The following is a description of a gene set: mouse primary BMDCs were stimulated with tlr ligands and gene expression changes were profiled on Affymetrix arrays from publication Amit I, Garber M, Chevrier N, Leite AP, Donner Y, Eisenhaure T, Guttman M, Grenier JK, Li W, Zuk O, Schubert LA, Birditt B, Shay T, Goren A, Zhang X, Smith Z, Deering R, McDonald RC, Cabili M, Bernstein BE, Rinn JL, Meissner A, Root DE, Hacohen N, Regev A (PMID 19729616) studied in species Homo sapiens Genes up-regulated in comparison of dendritic cells (DC) stimulated with Pam3Csk4 (TLR1/2 agonist) at 0.5 h versus those stimulated at 4 h. Human Gene Set: GSE17721_0.5H_VS_4H_PAM3CSK4_BMDC_UP, and this is the list of marker genes: PELO, PRR15, ASB4, CNR2, HMGB2, TEX2, HCFC1R1, C1D, EXT1, COMT, LAMTOR1, CASQ1, RPF2, GALK2, CBX6, RNF34, DUS1L, ARHGAP23, GALM, EID1, HSPH1, CRAT, NIPSNAP1, POLR2E, TRIM7, FTSJ1, TXNDC16, TSPAN14 (NCBI Gene Id 91090), SNX15, LFNG, FCGR2A, KLF10, ST6GALNAC4, UBR3, ZBTB45, FUT7, HSCB, FRRS1, ATG5, FCHSD1, ABHD17A, SP7, ATF6, MRPL15, NR1D2 (NCBI Gene Id 9975), ICAM2, APOBEC1, MRPL23, NUDCD2, HADH, C12orf57, ALDH18A1, CDCA7L, CAMK1D, ATP5IF1, TRPV4, GUCA1A, LAT2, GEMIN2, MAVS, TMEM53, TPGS1, PLCG2, TIMM13, RPS21, REX1BD, MEF2C, CAT, TNXB, ARFIP2, GORASP1, ELP1, TNS1, FANCL, AP1G2 (adaptor related protein complex 1 subunit gamma 2), FLT3LG, VPS41, IFIT3, MYCL, FCGRT, CLEC6A, DYNLT1, IGBP1, TTLL1, DBNDD2, SYT7, PKIB, GPNMB, MBOAT1, LRRC56, LPGAT1, TIMP2, GLRX3, UQCRC2, RAB7A, TLE5, S100A13, ZNF394, TRIO, PDXK, SDC3, SNAP47, AIF1, NOL12, HINT1, SLAMF6, SCAF8, PTPN18, EXOSC5, EI24, MYL11, LMAN2, ALDH9A1, SSBP1, TSPAN13, MRPS21, KLF13, ATP5F1E, HDDC2, TUBB2A, ATP6V1B2, RETREG2, RPL13, PALD1, SRMS, TBL1XR1, PCDH20, CDC37, MCM7, SAMM50, PDIA3, TSR2 (NCBI Gene Id 90121), ZBTB2, MED7, MFAP1, MRPL39, C19orf48P (chromosome 19 open reading frame 48, pseudogene), RASSF8, CUL7, PKIG, RAB3IL1, PIGP, PARP12, PON2, DNAJC3, FGD4, C2CD2L, HHEX, KIF9, KLHL22, RANBP1, HRAS, NDUFS3, ZBP1, RETREG1, TAL1, ST6GALNAC2, MBD1, YIPF1, DYNLL1, PRDM1, DDX39B, NDUFAF5, HLA-E, SASS6, MTFR1L, ACOX1, PRAF2, DGKA, SLC52A2, POT1, CD6, PALS2, ARG1, EHHADH, RPP21, NBEAL2, PGM1, PADI4, ARL6IP4, EVI5 (ecotropic viral integration site 5), RBM43, ATP6V1D, SUPT16H, CSF2RB, HMMR, CCR2, WAS, DDR2, RPS15A, HDAC1, TM9SF1, XRCC6, NAAA, NUFIP1, IFT81, SPN, ARL3, LAMTOR5, MCFD2